The following is a description of a gene set: Reactome Pathway: Highly calcium permeable postsynaptic nicotinic acetylcholine receptors part of: Postsynaptic nicotinic acetylcholine receptors studied in species Mus musculus This event has been computationally inferred from an event that has been demonstrated in another species.<p>The inference is based on the homology mapping from PANTHER. Briefly, reactions for which all involved PhysicalEntities (in input, output and catalyst) have a mapped orthologue/paralogue (for complexes at least 75% of components must have a mapping) are inferred to the other species. electronically inferred by orthology from the curated human pathway, and this is the list of marker genes: Chrna4, Chrna7, Chrnb2